The following is a description of a gene set: studied in species Homo sapiens Human Gene Set: MIR7111_5P from publication Chen Y, Wang X (PMID 31504780) Genes predicted to be targets of miRBase v22 microRNA hsa-miR-7111-5p in miRDB v6.0 with MirTarget v4 prediction scores > 80 (high confidence targets)., and this is the list of marker genes: SPIN3, ZBTB7B, ELAVL3, LRATD2, SMARCC2, SLC8A2, GAS7, ANKRD52, DMWD, AFAP1, FOXP4, DYRK1A, METTL9, ACTB, SLC7A8, MLLT6, LRRC59, CELF3, UBTF, ELK1, SYNGAP1, PHLPP1, CNTNAP1, FGF1, HMGA1, MAT1A, IHH (NCBI Gene Id 50819), SZRD1, TMEM54, PPP2R2D, RSU1, ANKRD26, CALR, SLC28A1, PIK3R2, IGSF11, PKNOX2, DVL3, PRC1, SERPINB7, LIX1L, DDX31, MECP2, MIEN1, DIRAS1, WIZ, FOXE1, ST13, TMEM222, NR1D1, BSDC1, LSAMP, FAM234A (family with sequence similarity 234 member A), PRKACA, POU2F2, PSMF1, ARRB2, FKBP8, HEYL, MNT (MAX network transcriptional repressor), CXADR, COL9A2, TCP11L1, RBMS3, SH3TC2, STIM1, C19orf12, BSN, CAMK1D, TFAP2B, ZDHHC15, CDK18, RERG, PHC2, H1-10, XYLB, PRR23A, DIRAS2, VPS37D, NOVA2, PLVAP, KCNJ10, KALRN, CTDSP1, MINK1, CAMKK2, FAM131B, CYP2B6, FBXO43, GATAD2B, PTHLH, PRR5L, BIRC2, TLE3, EN1, NFIX (nuclear factor I X), LRRC28, C9orf57, PLA2G2D, SELENON, SHISAL1, WNT3, PSME3, SHANK2, ADORA3, PPP1R9B, GRHL2, TMEM63B, PPT2, THRSP, SF3A2, CCDC97, JPH4, NFASC, RBM23, KMT2D, SRF, CTNND1, MFRP, ZNF691, FOXC1, MEX3A, CNST, FAM174B, TNFSF12, CES4A, NFIC, C6orf141, OLFML1, CPS1, LRP8, PPP2R5E, ACSL5, ZFC3H1, PLXNA4, DYSF, MPZ, MED19, RAB11FIP4, KCNC3, SNX29, SLC25A42 (NCBI Gene Id 57831), TMEM151A, TMEM198, NAPA (NCBI Gene Id 8775), CADM4, CDR2L, FADS2, SPRR1B, DEF8, RANBP10, PDLIM4, MTSS2, SOX13, PAX5, UBE2QL1, TBC1D10B, APLNR, PVALB, LCE1B, GPRC5A, WNK4, MAP7D1, DUSP10, GTPBP2, IL17RD, SLC9A8, CHRNA4, ITGA3, APBA1, ATAD3C, TRAM2, PPP2R1A, BMP1, CNIH2, DPYSL5, UBAP2L, IKZF4, TREML1, CLSTN1, SNPH, NHERF2, NLGN2, EPB41L1, PANX2, TCF7, MAP1A, SLC6A17, CASTOR2, STAT2, MYL12A, NAT16, ATP9A, CCDC102B, INAVA, PDE1B, PACS1, ZNRF2, SCGB2B2, PDX1, AP2M1 (adaptor related protein complex 2 subunit mu 1), COTL1, PCDHB11, STAC2